The following is a description of a gene set: studied in species Homo sapiens Human Gene Set: HP_RECURRENT_BRONCHITIS Recurrent bronchitis An increased susceptibility to bronchitis as manifested by a history of recurrent bronchitis., and this is the list of marker genes: TNFSF12, TNFRSF13C, FCHO1, ICOSLG, IRF2BP2, MS4A1, RNU4-2, NFKB1, IL2RG, MAGT1, DOCK11, ATM, CD19, SCNN1A, GAS8, CD81, USP26, ICOS, CD79A, IL17RA (interleukin 17 receptor A), IL10RB, MGP, TNFRSF13B (NCBI Gene Id 23495), TAP1, GNPTAB, DNAI1, RFX7, CR2, DNAJB13, NFKB2, DPP9, SMARCA2, CD79B, TAFAZZIN, DNAAF1 (dynein axonemal assembly factor 1), NBN, EGFR, RPGR, SEC61A1